Given this list of marker genes Gna13, Nepro, Ttll12, Tm2d3, Cpt2, Klf6 (NCBI Gene Id 97911), Sdc2, Ptprt, Zfp800 (NCBI Gene Id 637385), Eif3j2, Rwdd2b, Kpna1, Yes1, Gldc, Phc3, Vmac, Mprip, Ddah1, Snrpa, Cdc42se2, Pom121l2, Scn3a, Abracl, Rap2b, Agr3, Proz, Il22ra2, Vti1b, Siah1b, Zbtb44, Shprh, 4930563E22Rik, Stam, Siglecf, Hspa14, Slc33a1, Siah1a, Vmp1, Pja2, Commd6, Fstl5, Rif1, Ralb, Dab2, Prpf4b, Pcdh17, Klhl4, Lmo7, Lrch3, Cers3, Zfp846, Srsf1, Gvin3, Tmem200a, Wnt3, Gpr35, Mbnl2, Armc1, Gdpd1, Usp25, Kdm1b (lysine (K)-specific demethylase 1B), Ccdc93, Zbtb41, Actbl2, Zc3h12c, Ccpg1, Mtcl2, Smap1, here is a description of the gene set: from publication Chen Y, Wang X (PMID 31504780) studied in species Mus musculus Mouse Gene Set: MIR_6940_3P Genes predicted to be targets of miRBase v22 microRNA mmu_miR_6940_3p in miRDB v6.0 with MirTarget v4 prediction scores > 80 (high confidence targets).